Given this list of marker genes Ncbp3, Ncbp1, Phax, Snupn, Ncbp2, Ran, here is a description of the gene set: studied in species Mus musculus Mouse Gene Set: GOBP_SNRNA_TRANSPORT The directed movement of snRNA, small nuclear ribonucleic acid, into, out of or within a cell, or between cells, by means of some agent such as a transporter or pore.